The following is a description of a gene set: Genes down-regulated in ANBL-6 cell line (multiple myeloma, MM) expressing an activated form of NRAS off a plasmid vector compared to those co-cultured with bone marrow stromal cells. from publication Croonquist PA, Linden MA, Zhao F, Van Ness BG (PMID 12791645) Human Gene Set: CROONQUIST_NRAS_VS_STROMAL_STIMULATION_DN ANBL-6, a myeloma cell line, proliferates in response to interleukin 6 (IL-6) stimulation, coculture with bone marrow stromal cells, and when harboring a constitutively active mutant N-ras gene. Eighteen samples, including 4 IL-6-treated, 3 mutant N-ras-transfected, 3 normal stroma-stimulated, 2 multiple myeloma (MM) stroma-stimulated, and 6 untreated controls were profiled using microarrays interrogating genes. Global hierarchical clustering analysis distinguished at least 6 unique expression signatures. Notably, the different stimuli altered distinct functional gene programs. Class comparison analysis (P =.001) revealed genes (54% involved in cell cycle) that distinguished IL-6-stimulated versus nontreated samples. Eighty-seven genes distinguished stroma-stimulated versus IL-6-treated samples (22% encoded for extracellular matrix proteins). A total of genes distinguished N-ras transfectants versus IL-6-treated samples (26% involved in metabolism). A total of genes, 20% of these involved in signaling, distinguished N-ras from stroma-interacting samples. All 3 stimuli shared genes, mostly of metabolic function. Genes that distinguished MM1 from MM4 clinical groups were induced at least by one treatment. Notably, only genes (ETV5, DUSP6, and KIAA0735) are uniquely induced in mutant ras-containing cells. We have demonstrated gene expression patterns in myeloma cells that distinguish an intrinsic genetic transformation event and patterns derived from both soluble factors and cell contacts in the bone marrow microenvironment. species: Homo sapiens, and this is the list of marker genes: DLGAP5, LAMA4, SMARCD3, IER3, BCL6, FOSB, GJA1, NFKBIA, CDC6, STMN1, ARHGAP11A, CCN2, CCNF, H2BC11, COL16A1, CDK1, MCM2, SLC25A4, TRAIP, RECQL4, CDKN3, MKI67, DCLK1, CD81, COL6A3, H4C2, SBNO2, MCM3, DUSP1, THBS2, LAMB1, FOXM1, TK1, H2AX, CCNB2, TGFBI, CLC, NOTCH3, EZH2, JUN, SULF1, TSC22D1, SPARC, AURKA, CCNA2, NR4A2, RAD51AP1, VCAN, NASP, MCM7, TSC22D3, ID1, KIF2C, H2AC18, POSTN, IGFBP3, FOS, FSCN1, CKS1B, TOX, APOBEC3B, BASP1, PIM2, UBE2C (NCBI Gene Id 11065), CADPS, NUPR1, COL1A2, CDC45, HES1, HSPB6, HTT, SNRPA1, PPP1R15A, TPX2, PTTG1, SLC20A1, CENPE, IL6, PTGER3, PTP4A3, DEPP1, CENPA (NCBI Gene Id 1058), IER2, SFTPB, ACTA2, ITM2A, CDC20, IGFBP7, ZMIZ1, TROAP, AURKB, CCNB1, TPM2, IGFBP4 (insulin like growth factor binding protein 4), INPP5J, RPS4Y1, LUZP2